The following is a description of a gene set: Any process that stops, prevents, or reduces the frequency, rate or extent of axonogenesis. Human Gene Set: GOBP_NEGATIVE_REGULATION_OF_AXONOGENESIS studied in species Homo sapiens, and this is the list of marker genes: TNR, LRP4, NTN1, FGF13, HDAC6, SEMA6C, CDH1, RTN4, FSTL4, NRP1, ULK1, TRAK2, DIP2B, EPHA7, RTN4R, EPHB2, CDKL3, RNF6, PLXNA3, SPP1, DAB1, THY1, RGMA, TRIM46, DRAXIN, MAP2, ARHGAP4, GDI1, WNT3, WNT3A, IFRD1, PTPRS, WNT5A, PTEN, SEMA5A, SYNGAP1, ULK2, MCF2, BCL11A, MAG, SLIT1, PSEN1, SEMA3G, SEMA3F, SEMA6D, RYK, CDK5, SEMA4F, SPART, KIAA0319, EFNB3, RUFY3, MT3, DCC (DCC netrin 1 receptor)